The following is a description of a gene set: Chromosomal translocations that fuse the mixed lineage leukemia (MLL) gene with multiple partners typify acute leukemias of infancy as well as therapy-related leukemias. We utilized a conditional knockin strategy to bypass the embryonic lethality caused by MLL-CBP expression and to assess the immediate effects of induced MLL-CBP expression on hematopoiesis. Within days of activating MLL-CBP, the fusion protein selectively expanded granulocyte/macrophage progenitors (GMP) and enhanced their self-renewal/proliferation. MLL-CBP altered the gene expression program of GMP, upregulating a subset of genes including Hox a9. Inhibition of Hox a9 expression by RNA interference demonstrated that MLL-CBP required Hox a9 for its enhanced cell expansion. Following exposure to sublethal gamma-irradiation or N-ethyl-N-nitrosourea (ENU), MLL-CBP mice developed myelomonocytic hyperplasia and progressed to fatal myeloproliferative disorders. These represented the spectrum of therapy-induced acute myelomonocytic leukemia/chronic myelomonocytic leukemia/myelodysplastic/myeloproliferative disorder similar to that seen in humans possessing the t(11;16). This model of MLL-CBP therapy-related myeloproliferative disease demonstrates the selectivity of this MLL fusion for GMP cells and its ability to initiate leukemogenesis in conjunction with cooperating mutations. Top genes up-regulated in granulocyte/macrophage progenitors (GMP) upon expression of MLL-CBP fusion. from publication Wang J, Iwasaki H, Krivtsov A, Febbo PG, Thorner AR, Ernst P, Anastasiadou E, Kutok JL, Kogan SC, Zinkel SS, Fisher JK, Hess JL, Golub TR, Armstrong SA, Akashi K, Korsmeyer SJ (PMID 15635450) Mouse Gene Set: WANG_TARGETS_OF_MLL_CBP_FUSION_UP studied in species Mus musculus, and this is the list of marker genes: Rapgef3, Evi2a, Glg1, F10, Mrpl11, Tmco6, Pias4, Il12a, Rpl23a, Pglyrp1, Cpd, Rn18s-rs5, Slc38a3, Ezr, Dnah8, Atp6v1e1, Fam174b, Siah1a, Stk10, Itsn2, Mt1, Laptm4b, Laptm5, Trub2, Oosp1, Cela1, Cep350, Stac, Gtpbp2, Wfdc21, Fermt3, Ncam1, Ywhaz, Kif1b, Cd14, Lrg1, Rgs10, Cenpv, Vcam1, Ogfrl1, P2ry14 (NCBI Gene Id 320463), Adam15, Gpc1, Hoxa9, Nr2c2, Adcy3